Given this list of marker genes NR1D1, CD200, GRN, TREM2, MIR26A1, CD200R1, CST7, CX3CL1, IL4 (interleukin 4), SYT11, IGF1, TAFA3, LDLR, MIR181B1, PTPRC, TNFRSF1B, MIR181C, MIR195, SBNO1, here is a description of the gene set: Any process that stops, prevents or reduces the frequency, rate or extent of neuroinflammatory response. Human Gene Set: GOBP_NEGATIVE_REGULATION_OF_NEUROINFLAMMATORY_RESPONSE studied in species Homo sapiens